The following is a description of a gene set: Genes up-rgulated in CD34+ hematopoetic cells by expression of NUP98-HOXA9 fusion off a retroviral vector at 6h. NUP98-HOXA9, the chimeric protein resulting from the t(7;11)(p15;p15) chromosomal translocation, is a prototype of several NUP98 fusions that occur in myelodysplastic syndromes and acute myeloid leukemia. We examined its effect on differentiation, proliferation, and gene expression in primary human CD34+ hematopoietic cells. Colony-forming cell (CFC) assays in semisolid medium combined with morphologic examination and flow cytometric immunophenotyping revealed that NUP98-HOXA9 increased the numbers of erythroid precursors and impaired both myeloid and erythroid differentiation. In continuous liquid culture, cells transduced with NUP98-HOXA9 exhibited a biphasic growth curve with initial growth inhibition followed by enhanced long-term proliferation, suggesting an increase in the numbers of primitive self-renewing cells. This was confirmed by a dramatic increase in the numbers of long-term culture-initiating cells, the most primitive hematopoietic cells detectable in vitro. To understand the molecular mechanisms underlying the effects of NUP98-HOXA9 on hematopoietic cell proliferation and differentiation, oligonucleotide microarray analysis was done at several time points over 16 days, starting at 6 hours posttransduction. The early growth suppression was preceded by up-regulation of IFNbeta1 and accompanied by marked up-regulation of IFN-induced genes, peaking at 3 days posttransduction. In contrast, oncogenes such as homeobox transcription factors, FLT3, KIT, and WT1 peaked at 8 days or beyond, coinciding with increased proliferation. In addition, several putative tumor suppressors and genes associated with hematopoietic differentiation were repressed at later time points. These findings provide a comprehensive picture of the changes in proliferation, differentiation, and global gene expression that underlie the leukemic transformation of human hematopoietic cells by NUP98-HOXA9. species: Homo sapiens from publication Takeda A, Goolsby C, Yaseen NR (PMID 16818636) Human Gene Set: TAKEDA_TARGETS_OF_NUP98_HOXA9_FUSION_6HR_UP, and this is the list of marker genes: DACH1, SLC25A36 (solute carrier family 25 member 36), MSX1, SHISA2, CALCRL, XCL1, FGF7, HOXB3, PTPN13, SLCO4C1, SYBU, HPGD, GLYATL2, SCML1, PCDHB2, GNAI1, MACIR, EDN1, SPRED1, PCDH9, ITGB8, GLIPR1, HOXC6, TSPAN12, INPP4B, IFNB1, NRG4, HOXA4, STK4, STAT4, IL18, CAVIN2, GPR21, SEMA3C, LHFPL3-AS1, CD69, PBX3, IL7R, FRMD6, CDH9, HOXA5, PDE4DIP, LPAR6, PLN, PLCL1, JCHAIN, HOXA9, KMO, GAS2L3, TEX15, HOXB-AS3, FBXO22, KLF5, GASK1B, LIMCH1, EVI2A, NME7 (NCBI Gene Id 29922), ENSG00000304732, MS4A4A, TOX, MMP7, SCN2A, CEP70, CMAHP, P2RY12, OLFM3, ZNF503, PCOLCE2 (procollagen C-endopeptidase enhancer 2), HEATR5A, MECOM, SERPINI1, HOXA3, DLX2, ST6GALNAC1, USP32, PCDH17, PLA2G4A, MCTP1, CA8, GRK3, FLT3, C3orf80, DHRS9, FIGN, TYRP1, FKBP5 (FKBP prolyl isomerase 5), DMXL2